Given this list of marker genes NCBP3, EIF4E3 (NCBI Gene Id 317649), NCBP2L, CYFIP1, EIF4E2, EIF4E, AGO2, CYFIP2, NCBP2, MCTS1 (MCTS1 re-initiation and release factor), EIF4G3, EIF3D, DCPS, GEMIN5, IFIT5, EIF4E1B, EIF4A1, NCBP1, SNUPN, LARP1B, LARP1, here is a description of the gene set: Binding to a 7-methylguanosine (m7G) group or derivative located at the 5' end of an RNA molecule. Human Gene Set: GOMF_RNA_CAP_BINDING studied in species Homo sapiens